Given this list of marker genes GCDH, ETFA, ETFBKMT, ACAD10, IVD, ACADM, ETFB, ACADS, ACADL, ACAD11, ETFDH, ACADVL, here is a description of the gene set: Human Gene Set: GOBP_FATTY_ACID_BETA_OXIDATION_USING_ACYL_COA_DEHYDROGENASE A fatty acid beta-oxidation pathway in which the initial step of each oxidation cycle, which converts an acyl-CoA to a trans-2-enoyl-CoA, is catalyzed by acyl-CoA dehydrogenase; the electrons removed by oxidation pass through the respiratory chain to oxygen and leave H2O as the product. Fatty acid beta-oxidation begins with the addition of coenzyme A to a fatty acid, and ends when only two or three carbons remain (as acetyl-CoA or propionyl-CoA respectively). species: Homo sapiens